Given this list of marker genes Bmal1, H2-DMb2, Casp12, Lyz2, Serpina1b, Sprr2a1, Paip1, H2-DMa, Lama3, H2-DMb1, Defa31, Rpl14, H2-Aa, Ms4a4b, Clec4n, Itga8, Slc34a2, Pglyrp1, Prss30, Mt2, Slc5a8, Trim59, here is a description of the gene set: Mouse Gene Set: TUOMISTO_TUMOR_SUPPRESSION_BY_COL13A1_UP Epithelial cells of mucosal surfaces are critical for maintaining immune homeostasis by aiding in the discrimination of pathogenic and commensal microorganisms and modulating the activities of antigen-presenting cells and lymphocytes. Functional breakdowns resulting in chronic infection and inflammation are associated with the development of hematologic and solid neoplasms for which detailed pathogenetic mechanisms are poorly understood. Mice heterozygous for a transgene Col13a1(del) expressing a mutant collagen XIII developed clonal mature B-cell lineage lymphomas originating in mesenteric lymph nodes (MLN). The tumors were associated with T cells and macrophages. The incidence of disease was reduced 2-fold in transgenic mice raised under specific pathogen-free conditions, suggesting a role for infectious agents. The lymphomas did not express the mutant collagen XIII, indicating that its influence on tumorigenesis was B-cell extrinsic and likely to be associated with collagen XIII-positive tissues drained by the MLN. Studies of the small intestines of transgenic mice showed that the subepithelial basement membranes (BM) were highly abnormal and that they exhibited heightened expression of genes involved in immune responses. These results define collagen XIII-dependent maintenance of the intestinal BM as a previously unappreciated component of immune responses and a critical determinant of cancer susceptibility. Genes up-regulated in small intestine tissue from transgenic mice expressing a mutant form of COL13A1, compared to normal controls. species: Mus musculus from publication Tuomisto A, Sund M, Tahkola J, Latvanlehto A, Savolainen ER, Autio-Harmainen H, Liakka A, Sormunen R, Vuoristo J, West A, Lahesmaa R, Morse HC 3rd, Pihlajaniemi T (PMID 19074901)